The following is a description of a gene set: Reactome Pathway: Defective PMM2 causes PMM2-CDG studied in species Homo sapiens part of: Diseases associated with glycosylation precursor biosynthesis Phosphomannomutase 2 (PMM2) normally catalyses the isomerisation of mannose 6-phosphate (Man6P) to mannose 1-phosphate (Man1P) in the cytosol of cells. Man1P is a precursor in the synthesis of GDP-mannose and dolichol-phosphate-mannose, required for critical mannosyl transfer reactions in the N-glycosylation of proteins. Mutations in the PMM2 gene are one of the causes of Jaeken syndrome, a congenital disorder of glycosylation type 1a (PMM2-CDG, previously CDG-1a). PMM2-CDG was first described in Belgian identical twin sisters, characterized by psychomotor retardation and multiple serum glycoprotein abnormalities. Serum and CSF transferrin were found to be deficient in sialic acid. PMM2-CDG is the most common CDG disease subtype., and this is the list of marker genes: PMM2